Given this list of marker genes DIXDC1 (NCBI Gene Id 85458), S100A11, FAM149B1, PDS5A, MRPL49, ORC3, SRCAP, NADK, LARP7, LRRFIP1, GTF2E1, SUSD6, NTRK1, TUBB, IL2RB, UHRF2 (NCBI Gene Id 49857), HIPK1, TUBB4A, ILRUN, CREBZF, NKG7, GNGT1, CHD9, RBM14, ALOX5AP, RNH1, ARHGEF10, CCNG2, AHCYL1, ZNF160, CCL5, SLC7A6, GPSM2, HSF1, HARS2, DAG1, SGCG (sarcoglycan gamma), ABCD3, ANO3, CHEK1, LUM (NCBI Gene Id 4060), MTCL1, PRKCI, FAM168B, ZBTB33, CAPN2, SPINT2 (serine peptidase inhibitor, Kunitz type 2), PHYH, PF4, ANXA5, ATP6V0A2, SF3A3, MAT2A, ACSL3, HTR7P1 (5-hydroxytryptamine receptor 7 pseudogene 1), FCGRT, PER2, FCAR, SOCS1, SPTSSA, ATP2B1, PTPRA, SLC4A7, CD151, ZBTB18, SLC20A2, CYLD, ROCK1, TRMT1, NUP50, RAD54L, KDELR2, USP34 (NCBI Gene Id 9736), KLHL18, ATP6V1D, CCR4, SEC23IP, PPIA, CRIP1, TSPAN3, SLC5A3, DVL3, SLC16A1, PITPNA, SAC3D1, ACSL1, TIMP4, BASP1, HSD17B10, PLAA, PSD4, NME4, FLNA, UTP20, TRAIP, RNF103, PTPN14, VSNL1, YWHAZ, CENPF (NCBI Gene Id 51468), TSPAN6, REEP5, SEMA3D, TATDN2, CZIB, GCNT1, IL10RA, ITPK1, CSRNP2, PEPD, MATK, NT5E, AOAH, CCN6 (cellular communication network factor 6), MYOM2, LIPA, PCBD1, SPINT1, NAB1, TRPC1, RBM15B, SLC35D1, VAT1, PANK3, EVI2A, IFNW1, GUSBP3, BCL2L11, MPZL2, WAPL, GTF2H1, MICAL2, ACTN4, POGZ, LGALS3, APOBEC3C, COL6A3, DPYSL2 (NCBI Gene Id 1808), EGR1, ERCC2, GOLGA8A, CDC6 (NCBI Gene Id 990), CIITA, JMJD1C, MGST3, CAPG, RIPK1, KDM2A, QSOX1 (NCBI Gene Id 5768), NME6, PDGFRL, CAMK1, STXBP1, RPE65, ACTN1, PABPN1, MAPK1, MEGF9, UPP1, GM2A, FEZ2, S100A7, SLC30A1, TASOR, ATP1B1, GSTP1, ARF3, MAPK9, TUBB3, UBXN2B, KIAA0087, RGS19, EVI2B, FMO5, KLRC4, SIK2, IL4, GATA3, SKAP2, RSU1, GSN, PPP1R12B, TRPC6 (transient receptor potential cation channel subfamily C member 6), DCK, PIEZO1, CTSL, SPATA2, E2F3, MAP2K6 (mitogen-activated protein kinase kinase 6), MLEC, ZNF175, CAST (NCBI Gene Id 831), IL1RN, MAOA, SLC39A14, FLOT2, RRP15, PIAS4, here is a description of the gene set: To understand the functional relationship between brain dendritic cells (brain DCs) and other myeloid cells, we compared the gene expression profile of m/chDCs to that of bone marrow monocytes, brain microglia and classical spleen CD8+ and CD8- DCs. In order to obtain enough brain DCs for mRNA extraction, we expanded brain DCs with in vivo Flt3L treatment before purification. Genes up-regulated in spleen CD8- dendritic cells versus bone marrow monocytes. Human Gene Set: GSE29949_CD8_NEG_DC_SPLEEN_VS_MONOCYTE_BONE_MARROW_UP species: Homo sapiens from publication Anandasabapathy N, Victora GD, Meredith M, Feder R, Dong B, Kluger C, Yao K, Dustin ML, Nussenzweig MC, Steinman RM, Liu K (PMID 21788405)